Given this list of marker genes GDAP2, POU3F3, AMMECR1, DPP6, CGGBP1, AHR, PCDH19, CHRAC1 (NCBI Gene Id 54108), CAMTA1, HBP1, NOC3L, KALRN, FZD3, ATRN, BTBD1, KDM6A, USF3, CRELD2, MALT1, PAXBP1, ARID4B, IREB2, NKTR, CNOT6L, XPO7, MNX1, PARP3, CEPT1, FBXO43, SELENOK, MAGT1, CCNA2, PLCB4, KIAA1958, WAC, EIF4G3, SEMA6D (NCBI Gene Id 80031), SEC22C (NCBI Gene Id 9117), CEP128, PPM1L, SRSF12 (serine and arginine rich splicing factor 12), SYNGR3, RORA, F3, PMPCB, FNIP1, TSPAN2, NLN, CARMIL3, TES, CNR1, GRM3, CAND1, DOP1A, NPY1R, FAM9C, DENND4C, SIPA1L2 (signal induced proliferation associated 1 like 2), GTF3C3, DCC, ATG10, PNRC1, DGKH, NFYB, SLAIN2, CEP76, POLR2K, CACNB2, RAB3C, SRSF1, BARD1, OLFML2B, EIF4ENIF1, VEZF1, IGFBP1, PHIP, RABGGTB, SEPHS1, XPO1, STRBP, TGS1, PPP4R3B, POPDC3, ARIH1, LIN52, PPP1R14C, CACNA1C, NR3C1, SEC24A (SEC24 homolog A, COPII coat complex component), PHF2, BPNT2, BTAF1, CBX5, TUT4 (terminal uridylyl transferase 4), SGTB, ZBTB39, GRHL3, EPS8, OTUD6B, NCOA2, AP1S3, GTF2A1, MPHOSPH9, MTSS1, PTCH1, PARD6B, ZSWIM4, KLF3, DCUN1D4, SPOCK3, ARRDC3, MYCBP2, APAF1, DENND2B, PRR12, TBC1D15, UBL3, THAP12, ZFHX3, MED14, TP53BP1, SEPTIN9, KPNA3, ACBD5, SH3GL3, ARHGAP21, AUTS2, PIGX, PSIP1, ZNF558, TMED7, KIAA0408, CCDC66, MARK1, ZFPM2, ATF7IP, LATS1, NHLH2, ULK2, IKZF2, CDH20, RBPMS2, ANKRD31, KLHL15, TMX1, GNB4, AXL, UCHL5, B4GALT6 (NCBI Gene Id 9331), HOXA9, FRG2C, FYTTD1, APP, NUDT4, PPP2R5E, CREBZF, NCKAP1, CBLN4, KHDRBS1, LYSMD3, CORO1C, PPM1D, PEX5L, IPO7, AMN1, FRS2, FBXO34, EGFL6, EFCAB14, DCUN1D5, ACTR3, LRRC8B, TAOK1, PPP6C, RAB11FIP2, DVL2, ZNF521, GNA11, BDNF, SALL1 (spalt like transcription factor 1), PRPF8, AFF4, CADM1, AGFG1, VPS29, HEATR5B, WIPI1, FGF7, TCF3, SNAPC1, MAPK10, PDLIM5, ZNF236, BTF3L4, ZFY, SLC6A8, ITCH, PAFAH1B1, RWDD3, RYBP, LRP6, CILK1, EIF1AX, GRM8, ATP6V1H, ORC4, ELOVL7, PSD3, DCLK3, ANO4, MAGI1, HNRNPR, ADGRG2 (adhesion G protein-coupled receptor G2), B3GNT2, CREBRF, CLOCK, LZTS2, FAM107B, ZFYVE21, PDS5B, KIAA1217, GPR65 (G protein-coupled receptor 65), FOXO1, GPR34, EPB41L1, CNOT7, EDIL3, FAM222A, LANCL2, USP12, RIMKLB, AKAP9, ITGA6, ITGAV, NLGN1, GTF2I, MAP2K3, GPR158, SLC4A5, PTP4A1, PPP1R2, SYNCRIP, JAG2, GNA13, FAM117A, NDC1, BMPR2, RAB2A, KLHL35, JPH3, LMO3, CLCF1, VCPIP1, TP53, ZBTB1, PPP3CA, ACSL3, SPRED1, SLC25A24, TET3, SCN7A, PLG, COL11A1, JPH1, GOLGA1, ZFAND3, PPM1A, BEAN1, USP1, LRRC27, ASXL1, NUP160, ARHGAP44, HES1 (hes family bHLH transcription factor 1), IL20, NHS, RPS16, VASH2, GPR37, PDE5A, ZNF800, NEXMIF, NR5A2, NEUROG2, COL4A1, ACVR2B (NCBI Gene Id 93), HNRNPLL, MBD5, SCAF8, DOCK1, ATAD5, WDR37, ZNF616, MARCHF6, AKAP12, TMEM128 (NCBI Gene Id 85013), PARP15, BTBD7 (NCBI Gene Id 55727), HOOK3, ZBTB22, OAS2, LEF1, TRPM7, RNF144A, ARL17A, KIF11, CEMIP2, ZNF697, RAPH1 (Ras association (RalGDS/AF-6) and pleckstrin homology domains 1), TXNRD3, KMT2C, RTN1, ABI1, PPP1R21, MET, VAPA, AADAC, CPSF6, MYH10, UBAP2L, REL, TRIM63, UGT3A1, OSBPL3, SGO1, PUM2, RRAGD, ARHGEF33, QKI, PENK, TMEM132B, ANK3, TLN2, MPEG1, IQSEC2, ARHGAP12, WNT5A, SCAI, NPY, PGLYRP4, DCAF6, PRPF38B, GNAQ, FOXJ3, KDSR, CWC22, SOX9, SLC25A36, USP25, CCDC126, KIF1B, ID1, WAPL, ITM2B, HIVEP2, C8orf34, YTHDC1, RBM26, HMGXB4 (NCBI Gene Id 96789), ANKS1B, KCNH5, PCDH8, YIPF5, PLA2R1, NELFA, NECTIN1, IER2, ZNF532, EIF4A2, RAPGEF5, RAB10, PPP1R15B, CDK19, PTPRE, FUS, ORC2, SORBS1, USP34, EMP2, NFKBIA, SPPL3, JADE2, ZNF841, UBN1, RC3H1, PDAP1, LRRC1, NASP, MRS2, CRISPLD1, P2RY13, RICTOR, PLPP3, MATN2, FRMD4B, SELE, TMEM161B, TMEM185A, CRY1, GPC6, HS6ST2, TMEM267 (NCBI Gene Id 64417), POU4F1 (POU class 4 homeobox 1), FGFR2, OPA1, LRRC4, RBPJ (recombination signal binding protein for immunoglobulin kappa J region), EPC1, PHACTR2, MAST4, CDH11, CUL4B, ZBTB14, SKIL, KRAS, LVRN, HHIP, CPNE4, TNS3, DHX33, CNOT2, PCSK2, MMS22L, YY1, LIN9, SLMAP, NBEA (NCBI Gene Id 55091), KLF4, PTBP3, FYN, UBE2W, PNISR, POLR1B, ARAP2, NFIA, RHOT1, TENT5A, CD300LG, OXR1 (oxidation resistance 1), MBNL2, ATG2B (autophagy related 2B), SWSAP1, PAN3 (NCBI Gene Id 376186), CHD2, SFRP2, BRD1, UBR1, SEC23IP, TRIO, here is a description of the gene set: from publication Chen Y, Wang X (PMID 31504780) studied in species Homo sapiens Genes predicted to be targets of miRBase v22 microRNA hsa-miR-300 in miRDB v6.0 with MirTarget v4 prediction scores > 80 (high confidence targets). Human Gene Set: MIR300